Given this list of marker genes UPB1, SCN3A, RUSC2, ARHGEF9, CLN8, OTUD7A, PPFIBP1, GRM7, SLC32A1, CPLX1, COX4I1, KCNA2, CAPRIN1, NSRP1, P4HTM, CNKSR2, ZNF526, SLC12A6, NECAP1, ATP7A, ABAT, MFF, PIGL, MED17, CELF2, KCNA1, DALRD3, ERMARD, SCN9A, MOGS, CHRNB2, PIK3CA, SPTAN1, PDE2A, CHRNA4, CPA6, TBCK, DHDDS, TRAK1, GABRA2 (gamma-aminobutyric acid type A receptor subunit alpha2), DPM2, NAXD, WWOX, YEATS2, YME1L1, ARX, GAD1 (NCBI Gene Id 50977), PGAP3, DNM2, MTOR, ARFGEF2, NARS2, EEF1A2, POLG, GNAO1, GUF1, HID1, ASPA, STRADA, VARS1 (valyl-tRNA synthetase 1), GNB5, KCNC2, SIK1, CRH, CYFIP2, CUL3, FZR1, PIGV (phosphatidylinositol glycan anchor biosynthesis class V), STX1B, PACS2, CAMK2A (calcium/calmodulin dependent protein kinase II alpha), NPRL3, SLC18A3, ZNF148, LRPPRC, PIGT, DOCK7, TBC1D24, MGAT2, VARS2, TRIM8, KCNC1, BRAT1, CHD2, NUS1, PRICKLE1, SLC9A6, ATP6V0A1, NACC1, IQSEC2, CSTB, FRRS1L, CACNA2D1, SLC39A8, MDH1 (NCBI Gene Id 4190), IARS2, ALG13 (ALG13 UDP-N-acetylglucosaminyltransferase subunit), CLTCL1, BCKDK, KCNQ3, DNM1, AIMP2, CABP4, MECP2, KANSL1, MAPK10, ATAD1, SCN8A, ALDH4A1, ADGRG1 (NCBI Gene Id 9624), PLAA, UGDH, CTNNA2, SYT2, GABRB3, NF1, GABRG2, GABRA5, TIMM50, AMT, SCN1A, CCDC88A, ARFGEF1, PRPS1, PCDH19, COQ4, PHACTR1, JRK, PRRT2, SLC25A10, C1QBP, SLC13A5, NBEA (neurobeachin), HIBCH, PLCB1 (NCBI Gene Id 23236), CACNA1H, MYD88, AKT3, DOLK, CNTN2, PNKP, SV2A, SMC1A, CNTNAP2, ZNHIT3, ST3GAL3, WDR45, DMXL2, SETBP1, KCNMA1, ABCB7, FOXG1, SYNJ1, ACTL6B, PIGG, CACNA1E, ALDH7A1, LGI1, SETD1B, ITPR1, PLPBP, MAP1B, ATXN10, RPL10, ST3GAL5, GLS, ALG3, YWHAG, STXBP1, CDK19, CNPY3, HCN1 (hyperpolarization activated cyclic nucleotide gated potassium channel 1), PIGW (NCBI Gene Id 284098), GABRD, SPTBN1, D2HGDH, NTRK2, KCNB1, SATB1 (SATB homeobox 1), SLC6A1, SCN2A, MPDU1, PRKAG2, TUBB2A, GOSR2, KCNQ2, KCNJ11, NEUROD2, MYO9A, PIGA, SCN1B, GNB1, EFHC1, DEPDC5, UBA5, DCX, GRIA1, UFC1 (ubiquitin-fold modifier conjugating enzyme 1), ADK, MT-TL1, PIGP, ASNS, AGRN, CACNA1G, CACNA1A, ALG1, GRIN1, FBXO28, GFM2, GRIN2A, CLCN2, KCNT2, SAMD12, SCARB2, PI4K2A, SLC25A22, CUX2 (cut like homeobox 2), ESAM, AFG2A, HMGCL, TBC1D2B, PPP3CA, SLC2A1, SRPX2, PIDD1, GLUD1, CHAT, GABRB2, VAMP1, PIGO, EXOC8, PTS, HCFC1, LONP1, STARD7, GABBR2, GRIA3, TRAPPC12, TUBGCP2, AARS1, CLTC, DPAGT1 (dolichyl-phosphate N-acetylglucosaminephosphotransferase 1), ABCC8, ADARB1, PIGS, ALG2, SLC38A3, CLCN4, SZT2, NEDD4L, PSAT1, TFE3, TRPM3, ALG14, GABRA1, ARV1, NSF, FGF13, DPYD, APC2, SLC25A1, PIGY, ATP1A2, CILK1, RELN, ADGRV1, GCSH, CASK, GOLGA2, KCNT1, CDK5, NPRL2, IER3IP1 (NCBI Gene Id 55392), SYNGAP1, SLC5A7, CARS2, ATP1A3, GLYCTK, MED13L, EPM2A, ATP6V1A, CACNB4, CDKL5, SNAP25, PTPN23, PCDH12, NHLRC1, SLC35A2, UBE3A, SLC12A5, SYT1, SLC25A46, ATN1, TBL1XR1, GRIN2B, COL13A1, GRN, FGF12, AASS, AP3B2, LIPT2, ROGDI, PHGDH, RNF13, SUOX, SLC1A2, PRNP, PI4KA, PNPO, CAMSAP1, GABRB1, PGAP2, TGFB1, SLC1A4, CHRNA2, KCTD7, ALG11, PIGQ, NEXMIF, GRIN2D, PARS2, PAFAH1B1, AP2M1, NDUFAF8, PDHA1, CACNA1B, DAG1, here is a description of the gene set: Interictal refers to a period of time between epileptic seizures. Electroencephalographic (EEG) patterns are important in the differential diagnosis of epilepsy, and the EEG is almost always abnormal during a seizure. Some persons with seizures may show EEG abnormalities between seizures, while others do not. In some cases, multiple interictal EEGs must be recorded before an abnormality is observed. In most cases the electrographic pattern of seizure onset is completely different from the activity recorded during interictal discharge. species: Homo sapiens Interictal EEG abnormality Human Gene Set: HP_INTERICTAL_EEG_ABNORMALITY